The following is a description of a gene set: from publication Chen Y, Wang X (PMID 31504780) species: Mus musculus Mouse Gene Set: MIR_6915_5P Genes predicted to be targets of miRBase v22 microRNA mmu_miR_6915_5p in miRDB v6.0 with MirTarget v4 prediction scores > 80 (high confidence targets)., and this is the list of marker genes: Mob3c, Errfi1, Ttn, Vmp1, Sult1d1, Tmem245, C1ql1, Smndc1, Ehd2, Kdm5c, Spata1, Tcf24, Bmal2, Dnm2, Kirrel1, Hmg20a, Gpr3, Usp19, Hdlbp, Oxtr, Ddo, Ptbp3, Spock1, Cnot2, Ugt1a1, Tmod2, Tceal3, Sox8, E2f2, Cdk8, Pcyt1b, Ldlrap1, Ppp2r3d, Stmnd1, Ctdspl2, C87436, Slc25a5, Cers3, Gtpbp10, 4930544G11Rik, Ctdspl, Krt32, Slit2, Cytip, Gpcpd1, Ugt1a2, Ugt1a7c, Tceal6, Ugt1a10, Azi2, Tmem154, Prkacb, Fgfr1, Ugt1a5, F8a, Qki, Rtl5, Ugt1a6a, Ugt1a9, Pi4k2b, Rab5c, Garre1, Vim, Nsd3, Crim1, Arhgef17, Zfp46 (zinc finger protein 46), Ell2, Sh3bp5l, Foxn3, Arnt (aryl hydrocarbon receptor nuclear translocator), Utp25, Zbtb14, Slc7a11